Given this list of marker genes Glul, Dync1i2, Hook3, Dnai4, Dync2i2, Dnai3, Dnai2, Dync2i1, Bsn, Pvr, Dync1i1, Dnai1, here is a description of the gene set: Mouse Gene Set: GOMF_DYNEIN_LIGHT_CHAIN_BINDING Binding to a light chain of the dynein complex. species: Mus musculus